The following is a description of a gene set: Human Gene Set: REACTOME_MITOCHONDRIAL_FATTY_ACID_BETA_OXIDATION species: Homo sapiens Mitochondrial Fatty Acid Beta-Oxidation, and this is the list of marker genes: MMAA (metabolism of cobalamin associated A), ACBD6, ECHS1, ACSM6, ACADVL, HADHB, ACSM3, ACAA2 (NCBI Gene Id 147548), PCCB, ACOT1, ACADS, ACAD11, THEM4, ECI1, DBI, ACOT11 (NCBI Gene Id 91515), NDUFAB1, MMUT, ACOT7, THEM5, PCTP, ACOT9, ACOT12, MCEE (methylmalonyl-CoA epimerase), DECR1, ACSF2, ACAD10, ACBD7, HADH, ACADM, ACADL, MECR, ACOT2, PCCA, MCAT, HADHA, ACOT13